The following is a description of a gene set: species: Homo sapiens from publication Szatmari I, Pap A, Rühl R, Ma JX, Illarionov PA, Besra GS, Rajnavolgyi E, Dezso B, Nagy L (PMID 16982809) Genes down-regulated in monocyte-derived dendritic cells: rosiglitazone versus AM580. Human Gene Set: GSE5679_PPARG_LIGAND_ROSIGLITAZONE_VS_RARA_AGONIST_AM580_TREATED_DC_DN Our data indicated that activation of the PPARg nuclear receptor induces a retinoid response in human dendritic cells. In order to assess the contribution of retinoid signaling to the PPARg response we decided to use a combination of pharmacological activators and inhibitors of these pathways. Cells were treated with the synthetic PPARg ligand rosiglitazone (RSG), or with RSG along with the RARa antagonist (AGN193109) to block RARa mediated gene expression, or the RARa specific agonists (AM580) alone. This design allows one to determine if retinoid signaling is a downstream event of PPARg activation and what portion of PPARg regulated genes are regulated via induced retinoid signaling., and this is the list of marker genes: GPR137B, SCML4 (NCBI Gene Id 256380), TNK2, ITGA6, ARHGAP4 (Rho GTPase activating protein 4), TBC1D30, L1TD1, RAMP3, MGRN1, C5orf34, ARID5A, PGLYRP2, PGS1, STK10, GRK4, EMB, S1PR4, FAM3C, C19orf38, MYL12B, PITPNC1, SGMS1, SPACA9, DAXX (NCBI Gene Id 1616), SEPTIN4, PDCD2, SLC25A23, ITGA7, RPL17, ADIPOQ, SLAMF6, SLC12A6, GPR132, SGK1, C1orf185, CD96, HSH2D, ELF1, FMO5 (flavin containing dimethylaniline monoxygenase 5), TP53TG5, THADA, PLTP, IRAK3, TECPR1, GMFG, PIK3R5, IL7R, IRF9, S100A10, DCTN6, RNASEL, DOCK10, HOXA5, RREB1, ARMC7, PTPRE, TPR, CCM2, EIF4E3, SKAP2, GABRR2, OTULINL, PLEKHN1, RASGRP1, MYH9, EVI2B, IRF7, UTRN, GPNMB, PIK3R1, XAF1, NDOR1, ID3, USP18, KBTBD11, ACSS1, MOB3B, SUPT20H, EEIG1, INPP5B, RTP4, OSM, DEDD2, CTSA, TMEM71, RIN2, SLC4A7, SLC45A4, TBC1D10C, SAMD9L, RGS14, GBP7, LRTM1, SLC27A5, USP38, FHIP2A, ARID1A, F2RL1, DCAF7, SLC30A1, RFLNB, TRIM36, AKT3, TXNIP, TPP2, ITGA4, FGD3, ZNF646, RNF167, RYR1, LFNG, RNF19A, SMAD4, CCS, NXPE3, HVCN1, HS3ST3B1, SLC35C1, IL4R, SLC44A2, POSTN, ASB17, PSTK, S1PR1, GATA1, SNX14, CRLF3, MYOC, GAB3, MAST1 (NCBI Gene Id 22983), UBASH3B, BCL3, RAPGEF4, SHD, TNFSF10, SHARPIN, CLCF1, TMEM241, LIAT1, MBTD1, SATB1, KLHDC1, PMM2, ICAM2, NCK1, F12, PNPLA7, CD300LB, BMP2K (NCBI Gene Id 55589), MEX3B (mex-3 RNA binding family member B), CAPS2, DYRK2, RBM4B, RNF213, AQR, DGKA, CMPK2, ABCB1, IFIT1, PRKACB, ARHGEF18, TOR4A, ACAP1, CALCRL, NADK2, ASPHD2, RSRP1, GPCPD1, NDNF, ALOX12B, CLINT1, TTLL7, IRGM, ARHGEF1, SDCBP2, NCKAP5L, RASA3, RIGI, ZNFX1, FLOT1, ETV3, WFIKKN2, ZSCAN26, ZNF652, CCDC87, PELI1, SULF2, HUWE1, LEAP2, NDRG3, KLF2, PIK3CD, ZNF3, MCOLN3, DOP1B, CABCOCO1, EYA2, MGST2, ACP5, NOTCH4